The following is a description of a gene set: Human Gene Set: GSE17186_MEMORY_VS_CD21HIGH_TRANSITIONAL_BCELL_DN Genes down-regulated in B lymphocytes: memory versus transitional CR2 high. from publication Suryani S, Fulcher DA, Santner-Nanan B, Nanan R, Wong M, Shaw PJ, Gibson J, Williams A, Tangye SG (PMID 19965666) species: Homo sapiens Goals/objectives: to identify various gene expression in B cell subsets derived from human PBMC and cord blood, and this is the list of marker genes: UBE2J1, PRKACB, TNFRSF1B, DNPEP, EPS15, OTULIN, PAPSS1, ELF1, CCR7, RASAL1, TNRC6A, QSER1, CSRP1, NFAT5, PTCH1, ADGRE5, SMC4, TRIM59, CAPN15 (NCBI Gene Id 6650), MBP, IL18BP, IFNAR1, PRKCD, STAMBPL1, RILPL2, NUDT9, EPSTI1 (epithelial stromal interaction 1), XCL1, HERC4, MPC2, SGK3, RPA1 (replication protein A1), SNX9, SPATA13, PAK2, CHD4, CAPN2, TESK2, STAT6, ZAP70, DPP4, IL2RG, RIPK2, STAP1, DGKZ (diacylglycerol kinase zeta), GCH1, TG, LCMT1, IRF6, ZNF395, CD74, HIVEP1, ANKRD44, PDE8A, LAD1, TYK2, CTDSP1, ADNP, REEP5, NR4A1, RASSF5, WDR36, IRGM, DCAF11, MRTFA, SLC29A3, CDC25B, AHNAK, NDE1, TMEM243, STK10, CNOT6, TBL1X, ZNF451, IL10RB, PLAAT3, TCF7, S100A10, SLC2A3, GBP6, TAP1, UTP25, FAM117B (family with sequence similarity 117 member B), TMEM229B, CNTROB, SESN1, DECR1, CYTH3, MBOAT7, FCRL1, LITAF, CD4, HPCAL1, RASGRP1, CMTM7, STAT1, SLA, ATP6V1H, MIS18A, EPB41L2, GYPC, SH2B1, HARS2, PEX26, MGAT1, ABRACL, AKR1B1, FNBP1, CD83, KCNN4, CXCL10, IKBKE, IFIT2, IL7R, PRNP, KIF23, FOXP1, MYB, OGDH (NCBI Gene Id 4967), ATL3, PIK3CD, LACTB, CD96, SSBP3, MBNL1, RCSD1, PLEKHB2, PSME1, BMP5, SMPDL3A, MMD, C1orf35, LSP1, RGS3, TDRP, ADAM10, PSME2, SPN, NDFIP2, ASF1A, AP1G2, PCMT1, SPTBN1, PURG, ELOVL5, FASLG, DNAJC15, SEC61A1, BCL2L11, MGST2, NRIP1, PHLPP1, CRNKL1, STAT4, CHST15, TNFSF11, HIBADH, CD160, CD52, ARHGEF3, PKP4, CDC42SE2, ZMIZ2, FHL2, ADCY7, PSMB8, B4GALNT1, ACTN1 (actinin alpha 1), IFIH1, ITM2A, STAG2, FYB1, TOP2B, IRAG2, VAV3, RAI1, ADD3, PRR13, ATP11B, CD274, RASGRP2, ALDH3A2, NEK7, WBP1, HMOX2 (heme oxygenase 2), LBR, AP3B1, HDAC7, XYLT2, FAAH, FBXO4 (F-box protein 4), AGFG1, TIMM17B, VRK2, PHF21A, IFT140, PECAM1 (NCBI Gene Id 5175), IQGAP1, ASAP1, SH3KBP1